The following is a description of a gene set: Human Gene Set: MARIADASON_RESPONSE_TO_CURCUMIN_SULINDAC_5 The short-chain fatty acid butyrate, produced by microbial fermentation of dietary fiber in the large intestine, is a physiological regulator of major pathways of colonic epithelial cell maturation: cell cycle arrest, lineage-specific differentiation, and apoptosis. Microarray analysis of 8,063 sequences demonstrated a complex cascade of reprogramming of SW620 colonic epithelial cells upon treatment with butyrate characterized by the progressive recruitment of gene sets as a function of time. Comparison with the effects of trichostatin A, in conjunction with differences in the kinetics of alteration of histone acetylation induced by butyrate and trichostatin A, identified subsets of induced and repressed genes likely coordinately regulated by altered histone acetylation. The butyrate response was also compared in detail with that of sulindac, a nonsteroidal anti-inflammatory drug with significant chemopreventive activity for colon cancer, and curcumin, a component of mustard and curry structurally and functionally related to sulindac that also has chemopreventive activity. Although gene clusters were identified that showed similar responses to butyrate and sulindac, the data were characterized by the extensive differences in the effects of the two agents. This was striking for functional classes of genes involved in signaling pathways and in cell cycle progression, although butyrate and sulindac induce a similar G0-G1 arrest, elevation of beta-catenin-Tcf signaling, and apoptotic cascade. As regards cell cycle arrest, the underlying mechanism in response to butyrate was most similar to that of the Caco-2 cell line that had spontaneously undergone a G0-G1 arrest and least similar to the G2-M arrest stimulated by curcumin. Thus, high-throughput microarray analysis of gene expression profiles can be used to characterize and distinguish the mechanisms of response of colonic epithelial cells to physiological and pharmacological inducers of cell maturation. This has important implications for characterization of chemopreventive agents and recognition of potential toxicity and synergies. The data bases, gene clusters, and analyses are available at http:// sequence.aecom.yu.edu/genome/. from publication Mariadason JM, Corner GA, Augenlicht LH (PMID 10969808) Cluster 5: genes up-regulated in SW260 cells (colon cancer) by curcumin and sulindac. studied in species Homo sapiens, and this is the list of marker genes: XBP1, AGO2, LAD1, SMPD1, PSMB5, TARS1, BCL2L12, IFIT1, PCBP2 (NCBI Gene Id 5094), XPOT, MBTD1, FUS, DNAJA4, BTF3, ATF4, MLH1, STC2, INPP5A, ME1, KCNS2, ADK, ACADS (NCBI Gene Id 35), CKS1B